The following is a description of a gene set: studied in species Homo sapiens The transfer of multiple ADP-ribose residues from NAD to a protein amino acid, forming a poly(ADP-ribose) chain. Human Gene Set: GOBP_PROTEIN_POLY_ADP_RIBOSYLATION, and this is the list of marker genes: ZC3HAV1, PARP14, PARP2, TNKS, TNKS2, PARP3, PARP10, PARP15, PARP9, PARP1